Given this list of marker genes KIF1A, DIS3L2P1, LINC01173, ENSG00000307696, ALPP, SNORA75, AGAP1, HMGB1P3, RAB17, TMSB10P1, OR6B2, MIR5001, ATG4B, ECEL1P1, PPP1R7, MIR4777, LRRFIP1, SH3BP4, EIF4E2, UGT1A6, ENSG00000302063, RPS20P12, PRSS56, UGT1A13P, SP140, PDE6D, USP40, SCARNA5, UGT1A9, IQCA1, RPL28P2, ENSG00000124835, SNORD20, ATG16L1, GPC1, UGT1A3, RTP5, SP110, GAL3ST2, ENSG00000288080, CICP10, RAB17-DT, COPS8, SPATA3, GPR55, SNED1-AS1, ANO7, GPC1-AS1 (GPC1 antisense RNA 1, NCBI Gene Id 100130449), MAB21L4, RN7SL204P, LINC01940, NMUR1, OR6B3, GCSIR, MIR4441, CEP19P1, HES6, CAPN10, PPFIA1P1, ECEL1, RPL21P35, KCTD5P1, ENSG00000293136, ENSG00000224272, LINC03100, TPM3P8, RNU6-451P, RN7SL499P, AQP12B, RN7SL359P, MIR2467, RNU6-1140P, BOK, PASK, LINC01107, GIGYF2, TIGD1, COPS9, MSL3B, UGT1A1, IQCA1-AS1, SP140L, ALPI, NPPC, SPATA3-AS1, CAPN10-DT, LINC01881, FAM240C, TEX44, LINC01937, UGT1A10, ERFE, NRBF2P6, ENSG00000280119, DIS3L2, MLPH, AGXT, LINC00471, HDAC4-AS1, NCL, THAP4, ECEL1P2, ZBTB8OSP2, OR5S1P, GPR35, ING5, NGEF, ECEL1P3, DNAJB3, MTERF4, BANF1P3, UGT1A8, PRLH, RPL17P11, GBX2-AS1, CHRND, RNU6-268P, FARP2, RNU1-31P, RPL23AP88, ARL4C, ENSG00000235293, COPS7B, ENSG00000300430, B3GNT7, ESPNL, AGAP1-IT1, DGKD, MIR4786, OTOS, SNORD82, HJURP, SEPTIN2, LINC01907, NEU4, AQP12A, EEF1B2P7, DUSP28, PDCD1 (NCBI Gene Id 56179), LINC01880, MIR1244-1, OR9S24P, ILKAP, MIR1471, C2orf72, ACKR3, ANKMY1, ENSG00000235726, HTR2B, COPS8-DT, RBM44, EFHD1, ALPG (NCBI Gene Id 251), SPP2, NDUFA10, RNPEPL1, TRAF3IP1, SNED1, RN7SL32P, ITM2C, TWIST2, HSPE1P9, RN7SL834P, LINC02991, NEU2, MIR3133, RPS28P4 (NCBI Gene Id 649295), TRPM8, SAG, TANAR, PTMA, MIR4440, HIGD2AP1, RNU6-1333P, UGT1A7, LINC01237, MROH2A, LINC02610, ARMC9, ENSG00000288082, SNORD55, BOK-AS1, COX20P2, SCARNA6, SP100, CHRNG, MIR4269, RNU2-22P, UBE2F-SCLY, UGT1A12P, STK25, ENSG00000222001, MIR6811, RNU6-107P, DTYMK (deoxythymidylate kinase), RPL3P5, SNORC, RNA5SP122, RPL23AP26, KCNJ13, PSMD1, RAMP1, RNU6-234P, RNU7-127P, SEPTIN14P2 (septin 14 pseudogene 2), UGT1A2P, CAB39, RNU1-93P, ENSG00000306284, ASB1, COL6A3, UGT1A11P, KLHL30-AS1, CROCC2, HDAC4, UGT1A4, HDLBP, PER2, MIR562, UICLM, INPP5D, RNU6-1051P, D2HGDH, GBX2, LINC01891, MIR149, ASB18, KLHL30, UGT1A5, SCLY, UBE2F, here is a description of the gene set: Human Gene Set: chr2q37 species: Homo sapiens